Given this list of marker genes CYP26A1 (cytochrome P450 family 26 subfamily A member 1), CALR, DHRS3, CNOT1, CYP26B1, EZH2, CYP26C1, ZNF536, TGIF1, PRAME, here is a description of the gene set: Human Gene Set: GOBP_NEGATIVE_REGULATION_OF_RETINOIC_ACID_RECEPTOR_SIGNALING_PATHWAY species: Homo sapiens Any process that stops, prevents, or reduces the frequency, rate or extent of retinoic acid receptor signaling pathway activity.